The following is a description of a gene set: studied in species Mus musculus Mouse Gene Set: GOBP_STRIATED_MUSCLE_CELL_APOPTOTIC_PROCESS A form of programmed cell death induced by external or internal signals that trigger the activity of proteolytic caspases, whose actions dismantle a striated muscle cell and result in its death. Striated muscle cells make up striated muscle fibers which are divided by transverse bands into striations., and this is the list of marker genes: Ghrh, Nrg1, Pcmt1, Ambra1, Mdk, Igfbp3, Mff, Qki, Sirt4, Zfas1, Ltk, Atg7, Slc25a4, Cflar, Mapk8, Rapgef3, Hspb6, Trp53, Gch1, Hmgcr, Apaf1, Rgl2, Nupr1, Hsp90aa1, Pten, Cxcr2, Rps6ka2, Acot1, Sfrp2 (NCBI Gene Id 99743), Ppp1r10, Camk2a, Dynlt1f, Hey2, Sirt1, Notch1, Bnip3, Fbxo32, Capn1, Atg5, Trip10, Hand2, Bag3, Sirt5 (NCBI Gene Id 69760), Dynlt1a, Smad4, Eif5a, Myocd, Nfe2l2, Hspa8, Capn2, Bcl2, Dynlt1b, Adcy10 (adenylate cyclase 10), Map3k5, Gata4, Atp2a2, Pdpk1, Mfn2, Dynlt1c, Npm1, Gngt1, Pax8, Ptpn1, Bmpr1a, Gnb1, Hsf1, Trem1, Tigar, Casp12, Agt, Gata6, Nol3, Nkx2-5, Camk2d, Ilk, Eng, Kifap3, Pou4f2, Fndc1, Jak2